Given this list of marker genes CASP6, PROCA1, EIF4EBP1, POLM, RHBG, SLC25A53, MTMR10, ABO, AGTR2, IGHG1, TP53BP1, AP5B1, ZFP91, SH2D1A, LRRC31, PLEKHA8, NDFIP1, BICRA, SPACA7, FLNB, PAQR4, SMCO4, LDB2, NQO1, DYDC2, DOK2, CETN2, LRATD2, RBPJ, DGLUCY, FILIP1, FOCAD, BTN1A1, GSN, PLD6, CD81, PARD6B, PLEC, ZCCHC10, NUCB1, SLC35A2, PFKFB4, WDR90, ZCCHC4, PLCB3, MXRA8, EFHD1, MAP4, CALCRL, PLXNC1, TFAP4, CITED2, PHF10, UNC80, SGPP2, GTDC1, SAMD12, FEZ2, MCU, ITPRIPL1, PDE4D, SNX21, RSBN1, PTPN18, CGAS, CCR4 (NCBI Gene Id 1233), GGT6, RAC1, TNFRSF18, PTGER2, C1orf198, STAU2, SMUG1, GXYLT1, ITIH5, ZNF281, CD82, BLTP3B, NQO2, KSR1, DNAJC10, LYRM2, PDE4B, NRN1, CDYL2, ROBO4, NFASC, KRTAP21-1, MYBPHL, USP45, CD28 (CD28 molecule), KIFAP3, SLC2A3, SLC1A1, VSIG10, IL12B, CLYBL, BASP1, LY9, CMAS (cytidine monophosphate N-acetylneuraminic acid synthetase), TAGLN2 (NCBI Gene Id 8407), SMAD3, ASXL1, HS3ST1, P2RY10, GPR174, IFNB1, FOSL2, RAB32, GSTK1, GALNT4, SLC25A51, LACTB2, POGLUT1, SOCS3, LPCAT1, TP53I11, GRK5, PRDM1, AXIN2, SFR1, SERPING1, ARHGEF3, RAPH1, PLPP2, PGP, SGMS1, TECTA, PLXND1, CSTA, STAM, FRK, GRAP, APOBR, GARIN3, DUSP7, ITGB5, VAV3, CEP15, KTN1, GCOM1, BCAP31, LHX1, DAAM1, PTP4A2, F2RL2, MAPK4, WDFY2, SOS1, ALX4, RBBP9, SAMSN1, BATF, SLC48A1, KIAA0930, LYPLAL1, ACYP1, C2orf68, ENTPD6, MARCKS, IL4R, BSDC1, MRPL33, OSBPL8, NYNRIN, KCTD6, POLR2G, SH3PXD2B, RAP2C, ST8SIA6, PDE6D, GATA3 (NCBI Gene Id 84828), SLC17A1, STX3, STOX1, MID2, WSB2, DAP3, AOPEP, NCK2, ZNF22, DGKG, POLG, SEPTIN8, GYG1, PCCA, AUH, NSMCE1 (NSE1 homolog, SMC5-SMC6 complex component), TCP11, IFT81, RSPH1, AGPAT2, CEP164, GIPC2, KRT18, MTMR3, TREML2, FAM117B (NCBI Gene Id 65069), EP300, TMTC2, here is a description of the gene set: Genes up-regulated in comparsion of sfActCD4 versus sfActCD4TGF (see Fig. 1 in the paper for details). Human Gene Set: GSE7460_CTRL_VS_TGFB_TREATED_ACT_FOXP3_MUT_TCONV_UP species: Homo sapiens The transcription factor Foxp3 is usually considered the master regulator for the CD4+CD25+ from publication Hill JA, Feuerer M, Tash K, Haxhinasto S, Perez J, Melamed R, Mathis D, Benoist C (PMID 18024188)